The following is a description of a gene set: Human Gene Set: MORF_PAPSS1 studied in species Homo sapiens Neighborhood of PAPSS1 Neighborhood of PAPSS1 3'-phosphoadenosine 5'-phosphosulfate synthase 1 in the MORF expression compendium, and this is the list of marker genes: ACTR3, DYNLL1, IDH3G, EPRS1, CS (NCBI Gene Id 94822), TRAPPC3, ATXN10, LYPLA1, SRRM1, DGKZ, PAPSS1, SMNDC1, GANAB, SUMO2, TMED9, BMI1, AHCYL1, GAK, CALM2, BRD8, ARFGEF1, DCTD, CTDNEP1, VDAC3, ZNF638, NDUFC1 (NCBI Gene Id 4717), GPAA1, KHDRBS1, CLSTN1, TAX1BP1, AFG3L2, EIF4EBP2, RTCB (RNA 2',3'-cyclic phosphate and 5'-OH ligase), PTPRA, LRPPRC, EIF1AX, RPN1, VGLL4, HDAC2, PABPN1, HDAC1, CAPZB, HNRNPD, ARF4, XPO1, SEC63, VPS26A, VDAC2, RTN4, SEC24C, SH3BGRL, PDHB, PPT1, SREBF2, TCEA1, TNPO3 (transportin 3), MDH1, METAP1, STARD7, RAB6A, TIAL1, FBXW11, SMARCC2, GNG5, GNB2, GTF2A2, CANX, RNPEP, ANAPC5, ANXA7, PUM2, XRCC5, HADHB, SNRNP200, ESD, CAP1, RAD23A, TM9SF2, RNF44, ARPC5, GNB1, NAP1L4, TOMM70, ZNF131, DDX39B, RCHY1, KRIT1, SERP1, HADHA (hydroxyacyl-CoA dehydrogenase trifunctional multienzyme complex subunit alpha), KXD1, XPO7, FAM120A, MTDH, IFRD1, CAPZA1, AP3S1 (NCBI Gene Id 89412), GPN1, VAMP3, DNAJC8, YWHAQ, NONO, EFCAB14, G3BP2